The following is a description of a gene set: Human Gene Set: GOMF_DELAYED_RECTIFIER_POTASSIUM_CHANNEL_ACTIVITY Enables the transmembrane transfer of a potassium ion by a delayed rectifying voltage-gated channel. A delayed rectifying current-voltage relation is one where channel activation kinetics are time-dependent, and inactivation is slow. studied in species Homo sapiens, and this is the list of marker genes: KCNH8, KCNH1, KCNH2, KCNH5, KCNE5, KCNA7, KCNE1, KCNA10 (NCBI Gene Id 3744), KCNE2, KCNA2, KCNC2, KCNC4, KCNS3, KCNA1, KCNA3, KCNE3, KCNE4, KCNA6, KCNA5, KCNB1, KCNC3, KCNQ1, KCNA4, KCNC1, KCNB2